Given this list of marker genes ZNRF1, SP1, PSMA6, SOCS7, ZNF318, UTP11, FMC1, CDC20, ZNF25, NNT, NUPR1, HS6ST1, MARCKSL1, AKR1B1 (NCBI Gene Id 231), FLNB, MED17 (mediator complex subunit 17), GFM1, LYAR, ERI2, GPANK1, CCR6, CCT5, DNMT3B, FMR1, IARS1 (isoleucyl-tRNA synthetase 1), CNEP1R1, DNAJC21, CDC45, NRBF2 (NCBI Gene Id 91155), GOLGA3, IK, EEF1B2, GJA4, HSF1, PSMD8, TACC3, BRIP1, IFRD1, SMC4, HIPK3, PRKCI, TRAIP, HUS1, LIX1L, ZNF48, OSBPL3, CDC16, LRRC40, AFG2B, DDHD1, XRCC6, ASF1A, ARMCX6, SLA, GLCE, NFKB2, MLLT3, TMEM218, ARNT, TEX30, CNIH1, CNTROB (centrobin, centriole duplication and spindle assembly protein), YAP1, ECSCR, CEP76, ETAA1, CBX2, TENT4A, LYL1, RBBP5, SNHG32, NSUN6, SNRPF, TCERG1, RCOR3, CYTH1, KNTC1, TOPBP1, NEURL1B, UTP3, AP3D1, BORA, MIB2, SMNDC1 (NCBI Gene Id 10285), PALB2, SMC2, TMED3, SIRT1, KTN1, ECHDC1, NBEAL1, NUDCD2, EPRS1, CCDC90B, CLIC4, DBP, HIVEP2, PTPRA, MMS22L, MLST8, PPM1F, FOXN2, ERCC6L, BMAL1, SSRP1, ASPM, TBC1D12, E2F2, SNX13 (sorting nexin 13), ANGPTL4, HP1BP3, RSPRY1, PI4K2B, RCOR2, REXO4, MAPK14, CENPU, FAM110A, CDCA3, NAP1L1, MFN1, TRIM68, SYPL1, HDGF, CDK1, MYCN, PPP2R3C, DNER, CPD, SZT2, HPS4, YAF2, COX16, SLC35C2, KIF20A, GTF2IRD1, GPSM2, SLC38A2, ARHGAP11A, SLC3A2, DNTTIP2, TULP3, PCBP2, C5orf46, AIMP1, UBE4B, CHKB, TATDN1, ZNF7, TMPO, SP4, HSPA4L, CKAP2L, ANLN, ENPP1, RALA, NUP37, EIF3A, PHF20 (NCBI Gene Id 80330), FBXO45 (NCBI Gene Id 414772), KDM6A, CKS1B, ABHD15, WDR62, SELENOS, RPS6KA5, EPC2, CFAP299, CDC25C, MARCHF3, CLNS1A, UBE2C, KIF2A, ZWILCH, TOX2, ORC5, ZFP36L1, SENP6, SLC9A5, GALNT3, JAK2, CRBN, KCNT2, ANP32B, METTL1, OLA1, ZNF799, TMEM126A (NCBI Gene Id 84233), RAB10, PIBF1, ZNF490, AURKA, GOT2, PWWP2A, NUSAP1, SKIC3, PRPF8, TEX10, ZNF652 (NCBI Gene Id 22834), KIF20B, here is a description of the gene set: from publication Bhattacharyya S, Deb J, Patra AK, Thuy Pham DA, Chen W, Vaeth M, Berberich-Siebelt F, Klein-Hessling S, Lamperti ED, Reifenberg K, Jellusova J, Schweizer A, Nitschke L, Leich E, Rosenwald A, Brunner C, Engelmann S, Bommhardt U, Avots A, Müller MR, Kondo E, Serfling E (PMID 21464221) Triggering of B cell receptors (BCR) induces a massive synthesis of NFATc1 in splenic B cells. By inactivating the Nfatc1 gene and re-expressing NFATc1 we show that NFATc1 levels are critical for the survival of splenic B cells upon BCR stimulation. NFATc1 ablation led to decreased BCR-induced Ca++ flux and proliferation of splenic B cells, increased apoptosis and suppressed germinal centre formation and immunoglobulin class switch by T cell-independent antigens. By controlling IL-10 synthesis in B cells, NFATc1 supported the proliferation and IL-2 synthesis of T cells in vitro and appeared to contribute to the mild clinical course of Experimental Autoimmune Encephalomyelitis in mice bearing NFATc1-/- B cells. These data indicate NFATc1 as a key factor controlling B cell function. species: Homo sapiens Genes down-regulated in B lymphocytes: wildtype versus NFATC1 knockout. Human Gene Set: GSE21063_WT_VS_NFATC1_KO_BCELL_DN